Given this list of marker genes Cenpj, Stil, Mapk15, Dync1h1, Sass6, Spag5, Gpsm2, Numa1, here is a description of the gene set: Any process that activates or increases the frequency, rate or extent of spindle assembly. Mouse Gene Set: GOBP_POSITIVE_REGULATION_OF_SPINDLE_ASSEMBLY species: Mus musculus